The following is a description of a gene set: A type of intermediate filament, typically made up of one or more of the proteins vimentin, desmin, glial fibrillary acidic protein (GFAP), and peripherin. Unlike the keratins, the type III proteins can form both homo- and heteropolymeric IF filaments. Mouse Gene Set: GOCC_TYPE_III_INTERMEDIATE_FILAMENT studied in species Mus musculus, and this is the list of marker genes: Dst (dystonin), Prph, Vim (vimentin), Upp2, Des, Vmac